The following is a description of a gene set: Mouse Gene Set: GOBP_INFLAMMATORY_RESPONSE species: Mus musculus The immediate defensive reaction (by vertebrate tissue) to infection or injury caused by chemical or physical agents. The process is characterized by local vasodilation, extravasation of plasma into intercellular spaces and accumulation of white blood cells and macrophages., and this is the list of marker genes: Trav7-2, Stat3, Hck, Alox5, Elf3, Ccl12, Il17f, Trim65, Tspan2, Ptn, Pik3ap1, Gpx2, Bcl6, Cxcl9, Metrnl, Il17d, Spata2, Fcgr3, Ccl26, Tbc1d23 (NCBI Gene Id 98049), Nfkbiz, Il31ra, Ticam2, Cnr2, Map3k7, Igf1 (NCBI Gene Id 320499), Tlr9, Pnma1, Siglece (sialic acid binding Ig-like lectin E), Aif1, C1qa, Abcc1, Uaca, Npy, Elf4, Ripk1, Saa1, Scyl1 (NCBI Gene Id 98159), Tollip, Ptger1, Pmp22, Nlrp4c, Ptger2, Cd36, Il18rap, Mrgpra3, Fcgr2b, Tirap, Arel1, Ptger4, Spink7, C1qtnf3, Gzmn, C1qtnf12, Rtn4, Gper1, Hfe, Ptafr, Syt11, Hdac5, Ccr1l1, S100a8, Itgb2l, Nr3c1, Fndc4, Ahcyl, Plgrkt, Ifi203, Cst7, Aimp1, Mapk14, Ghsr, Abcd1 (ATP-binding cassette, sub-family D member 1), Sod1, Nkiras2, Ywhaz, Nlrp10, Lep, Gpr33, Il36g, Mcemp1, Il22ra1, Jam3, Ticam1 (NCBI Gene Id 224899), Cxcl5, Ccn4, Fpr1, Selp, Tnfsf18, Il17rb, Stab1, Ccl7, Chia1, Camk1d, Cd276, Ccr5, Nek7, Clu, Ugt1a1, Tbxa2r, Lats1, Tnc, Armh4, Ephb2, Elp6, Stard7, Serpina1b, S100a9, Brcc3dc, Ggt5 (NCBI Gene Id 23887), Lrrk2, Csf1r, Il1rap, Mmp8 (matrix metallopeptidase 8), Cyld, Lpcat3, Ccr4, Ccl6, Tlr1, Ptgdr, Clec7a, Fcer1g, Nlrp3, Itgav, Stap1, Il1rl2, Naip5, Zdhhc1, Umod, Nlrp12, Cxcl1, Stmp1, Cd44, Pglyrp1, Nkg7, C4b, Lias, Cela1, Calhm6, Ptgis, Il27, Il36b, Lat (NCBI Gene Id 16797), Lats2, Tlr11, Tff2 (NCBI Gene Id 21785), Apip, Fcgr4, Zfp580, Ccl9, Tusc2, Aim2, Ulk4, Lta, Gzma, Hmgb1, Ncf1, Ccrl2, Ndp, Cyp19a1, Cd24a (CD24a antigen), Nfe2l1, Htr2a, Hdac7, Il34, Clock, Cd163, Gbp3, Hmox1, Gpr31b, Hmga1, Ecm1, Hk1, Prkca, Scnn1b, Reg3g, Ly86, Vps13a, Vwf, Naip6, Cebpb, Dab2ip, Fosl2, Fpr2, Adcyap1, Il2, Tfr2 (transferrin receptor 2), Setd6, App, Vnn1, Tmem258, Per1, Cxcl13, Abcd2, Mapk8, Casp8, Wdr83, Hdac9, Relb, Il6, Mep1b, Git1, Sigirr, Lgals1 (lectin, galactose binding, soluble 1), Fpr-rs4, Mapkapk2, F3, Wnk4, Tlr13, Cnr1, Cuedc2, Letmd1, Nlrc3, Ufl1, Map2k3, Trem2, Myo5a, Kdm6b, Dsg2, Chst4, Il33, Chst1, Ets1, Ifi213, Chi3l1, Gpr141, Reg3b, Bap1, Ppbp, Mtor, Fabp4, Foxp1, Enpp1, Mir7578, Ptpn2, Tgfb1 (transforming growth factor, beta 1), Ptpn6, Ak7, Clec12a, Adora3, Agtr1b, Fpr-rs7 (formyl peptide receptor, related sequence 7), Tnfrsf11a (tumor necrosis factor receptor superfamily, member 11a, NFKB activator), Casp1, Cx3cl1, Mir124a-1hg, Cfh, Ifi208, Il23a, Ext1, Ddt, Appl1, Fut7, Trim14, Irf5, Acvr1, Mcph1, Enpp3, Slc7a2, Ccl22, Il1rn, Nfix, Gsdme, Cd96, Mefv, Ctla2a, Scgb1a1, Ano6, Lilrb4b, Fcer1a, Pld4, Vcam1, Cxcl11, Orm2, Ptgir, Gzmc, Krt1, Plaa, Eif2ak1, Agtr2, Nrros, Camk4, Egfr, Naip2, Alox5ap, Serpinf2, S100a7a, Il5ra, Ccl3, Nmi, Otulin, S1pr3, Mfhas1, Usp50, Lilrb4a, Tyro3, Gbp5, Gsdmd, Cxcl3, Mkrn2, Kng1, Cxcl2, Ttbk1, Ackr2, Gsdmc3, Tcirg1, Nlrp4b, Reg3a, Ccl5, Psmb4, Csf1, Dicer1, Ctnnbip1, Tnfaip6, Eif2ak2, Nlrp14, Cd40lg, Il22, Nlrp4e, Ppara, Tac4, Bdkrb2, Ifngr1, Bcr, Kars1, Lgals2, Psen2, Shpk, Cptp, Fxr1, Ttc39aos1, Trim21, Chst2, Il17ra, Nfkbia, Trim55, Lrrd1, Fads2, Ifi207, Fanca, Cd5l, Hspa8, Alox15, Kcnj8, Fpr3, Zdhhc12, Slamf1, Atat1, Ankrd42, Ackr1 (atypical chemokine receptor 1 (Duffy blood group)), Gstp1, Saa2, Mas1, Pdcd10, Serpinb9, Large1, Pxk, Dpp9, Cxcr2, Sbno1, Gbp2b, Nfe2l2, Hgf, Map3k20, Vamp8, Ahr, Lipa, Smad1, Fchsd1, Seh1l, Lgals9, Ptger3, Pla2g3, Foxf1, Tpsb2, Polb (NCBI Gene Id 320892), Gja1, Pstpip1 (NCBI Gene Id 19200, proline-serine-threonine phosphatase-interacting protein 1), Chil6, Spn, Zdhhc9, Pbxip1, Il17rc, Cybb, Vps54, Ptpn22, Blvra (biliverdin reductase A), Trpv1, Casp12 (caspase 12), Rel, Cd2ap, Fem1al, Ido1, Sema7a, Tlr3, Hc, Nlrp1b, Tnfsf4 (tumor necrosis factor (ligand) superfamily, member 4), Itih4, Cxcr6, Trim11, Zdhhc5, Cd68, Atrn, Nppa, Lilra5, Timp1 (NCBI Gene Id 21857), Wfdc1, Plcg2, Il22ra2, Casp3, Ccl8, Cd200l2, Hyal3, Tlr5, Acer3, Jak2, Ffar2, Cntf, Gprc5b, Mir7116, Ggt1, P2rx7, Odam, Gzmb, Ash1l, Rab44, Irgm1, Celf1, Ndufs4, Fam76b, Adam8, Nlrp1a, Ifi209, Igtp, F12, Gps2, Npy5r, Ccn3, Fpr-rs6, Pla2g2a, Tlr8, Rps6ka5, Cd300a, Il17re, Il1r1, H2bc1, Itgam, Gpx1, Lacc1, Dpep1, Elane, Trpv4, Traf3ip2, Havcr2 (NCBI Gene Id 268402), Mif, Ctss, Appl2, Duoxa1, Pomgnt1, Mir21a, Notch1, Epo, Grn, Il16, Apoa1 (NCBI Gene Id 11806), Syk, Rb1, Zc3h12a, F2rl1, Ier3, Ly96, Casp4, Scn9a, Abhd17a, Il23r, Ezh2, Camp, Gm15441, Klk1b1, Bmp6, Nlrc4, Il18, Aoah, Fam210b, Rora, Orm3, Prkcz, Psen1, Nlrp6, Tnfsf11, Trim45, Fkrp, Il20rb, Pja2, Ccl28, Hyal2, Ccl17, Ffar3, Slamf8, Lrp1, Fcgr1, C5ar2, Kcnn4, Proc, Foxp3 (NCBI Gene Id 20371), Klkb1, Il17b, Ephx2, Ass1, Epha2, Tab2, Pomt2, Xcl1, C3ar1, Ahsg, Tmsb4x, Prcp, Cd6, Cxcr3, Hyal1, Mir147, Cd81, Mecom, Ahcy, Rps6ka4, Il4ra, Nos2, Socs3, Pf4, Crlf2, F2r, Jun (NCBI Gene Id 16476), Apoe, Anxa1, Adcy1, Lpl, Tyrobp, Snap23 (synaptosomal-associated protein 23), Rbpj, Tnip1, Ccdc39, Sting1, Chil3, Sphk1, Plp1 (proteolipid protein (myelin) 1), Dmd, Brd4, Fn1, Lyn, Tradd, Lxn, Cxcl17, Cysltr1, Rictor, Nlrp5, Tnf, Il1r2, Chrna7, Afap1l2, Cd200r1, Ap3b1, Tac1, Col6a1 (NCBI Gene Id 12833), Nlrp4a, Ifi35, Stat5a, Ndfip1, Pla2g7, Ccr6, Stk39, Gsdma, Acod1, Ednrb (endothelin receptor type B), Ighg1, Gsdma2, Gkn2, Plscr1, Epg5, Rela, P2rx1, Daglb, Ccr7, Bpgm, Mir301, Zfp35, Orm1, Axl, Il1a, Osm, Rabgef1, Trp73, Cp, Dnase1, Acp5, Bcl6b, Gm12250, Hspa12a, Tlr12, Cxcl15, Mndal, Cd200r4, Hif1a, Fasn, Irf3, Mir155, Il25, Naglu, C2cd4b, Lamp2, Ifng, Mir324, Selenos, Chil4, Gsdmc, Gm5849, Muc19, Tlr4 (toll-like receptor 4), Slc39a8, Casp6, Msmp (microseminoprotein, prostate associated), Il1f10, Tlr7, Cd180, Ccl19, Cd47, Cd28, Dnase1l3, Ephb6, Esr1, Il4, Serpinb1a, Snca, Epsti1, Nlrp4f, Zp3, Snx4, Gsdmc2, Itgb2, Ccr1, Il17c, F8, Napepld, Zeb2, Dagla, Extl3, Nod2, Dhrs7b, Lcn10, Adora2b, Pde5a, Trim31, Drosha, Irgm2, Mavs, Psma1, Tmed2, Cd200, Adcy8, Fem1a, Gnat2, Tarm1, Socs5, Ctsc, Cers6, Il36a, Smad3, Kprp, Tafa3, Arnt, Nr1h5, Nfkb1 (NCBI Gene Id 18033), Themis2, Lrrc25 (NCBI Gene Id 211228), Nlrx1, Duoxa2, Hrh4, Ins1, Pglyrp2, Kit, Cx3cr1, F2, Ccl11, Tnfrsf4, H2-T23, Akt1, Serpina3n, Trex1, Btk, Nr1h2, Vps35, Nlrp9b, Fut4, Zbp1, Gbp2, Loxl3, Zfp36 (zinc finger protein 36), Mapk9, Clec10a, Usp18, Csrp3, Hnrnpa0, Ifnb1, Ppard, Wnt5a (NCBI Gene Id 77565), Ccl4, Nupr1, Krt16, Tfrc, Naip1, Nr1d1, Ffar4, Ptges, Lbp, Gata3, Scn11a, Ighe, Adora2a, Prkcq (NCBI Gene Id 99373), Adcy7, Serpine1, Nr1h3, Slc11a1, Trim30a, Siglecg, Prkd1, Adam17, Ddx3x, Dhx9, Card9, Macir, Sharpin, Ninj1, Gpr4, Ccr3, Nlrp9a, Cyp26b1 (cytochrome P450, family 26, subfamily b, polypeptide 1), Akna (AT-hook transcription factor), Adipoq, Rarres2, Saa3, Mdk, Bmpr1b, Tlr6, Il10, Lrrc19, Gpr17, Mgll, Il36rn, Pparg, Cul3, Fam3c, Cyba, Nr1d2, Cebpa, Ccl20, Stat5b, Gsdma3, Il18r1, Ptgfr, Apod, Ldlr, Scyl3, Pla2g10, Tnfaip3 (NCBI Gene Id 21929), Il17a, Pld3, Agtr1a (NCBI Gene Id 72294), Sucnr1, Dusp10, Rasgrp1 (RAS guanyl releasing protein 1), Ndst1, Ptgs2, Map3k8, Agr2 (anterior gradient 2), Il2ra, Atm, Ogt, Hp, Myd88, Itgb6, Fancd2, Abr, Brcc3 (NCBI Gene Id 210766), Tnfrsf1b, Cdh5, Adora1, Kcnk13, Mir883b, Il1rl1, Il13, C2cd4a, Smo, Chil5, Pla2g5, Cd14, Rps19, Ccl21b, Cxcl10, Fpr-rs3, Ccl25, Ins2, Ppp2ca, Camk2n1 (NCBI Gene Id 66259), Sirpa, Ighg2b, Abhd12 (abhydrolase domain containing 12), Cd200r3, Notch2, Crp, B4galt1, Cntnap2, Ccr2, Sbno2, Bst1, Hmgb2, Serpina1a, Pycard, Crh, Cd200l1, Il10ra, Pla2g2d, Adamts12, C3, Tlr2, Ifi203-ps, Slc18a2, Sirt2, Fam114a1, Icam1, Pbk, Pik3cg, Fbxl2, Rhbdd3, Nt5e, Mark4, Il12b, Il1b, Tslp, Hspa4, Ager, Ccl27a, Kdm4d, Ccl21a, Lrfn5, Park7, Chid1, Tnip2, Setd4, Hps1, Cd200r2 (Cd200 receptor 2), Tspan18, Ccl24, Parp4, Nampt, Rap1gds1, Mvk, Fosl1, Tnfrsf1a, Nfkbid, Ccl1, Mylk3, Itgb1, Agt, Pdcd4 (programmed cell death 4), Nr1h4, Cmklr1, C5ar1, Isl1, Fbxw10, Hamp, Nr5a2, Calca, Pla2g2e, Nr4a1, Slc9a6, Pde2a, Aoc3, Gsdmc4, Dhx33, Ifi206, Calhm2, Ghrl, Kpna6, Clcf1, Cma1, Bmp2, Nlrp2, Nfkbib, Cr2, Ifi214, Smpdl3b, Ppp1r13l, Gpsm3, Crhbp, A2m, Unc13d, Csnk1a1, Il22b, Prdx2, Bdkrb1, Ifngr2, Ccl2, Tril, Olr1, Tnfaip8l2, Nlrp9c, Pik3cd, Ada, Thbs1